The following is a description of a gene set: studied in species Homo sapiens Any process that activates or increases the frequency, rate or extent of signaling pathways initiated by the cross-linking of an antigen receptor on a B cell. Human Gene Set: GOBP_POSITIVE_REGULATION_OF_B_CELL_RECEPTOR_SIGNALING_PATHWAY, and this is the list of marker genes: SLC39A10 (NCBI Gene Id 57181), FOXP1, MIR18A, CD81, NFAM1 (NCBI Gene Id 150372), PRKCH, STAP1, CMTM3, MIR19A